The following is a description of a gene set: studied in species Mus musculus Mouse Gene Set: GOBP_CARDIAC_CHAMBER_DEVELOPMENT The progression of a cardiac chamber over time, from its formation to the mature structure. A cardiac chamber is an enclosed cavity within the heart., and this is the list of marker genes: Gsk3a, Gja5, Fhl2, Mir20a, Bmp7, Hand2, Fgfr2, Slit3 (slit guidance ligand 3), Ovol2, Lrp2, Mesp1, Myl2, Npy2r, Cpe, Zmpste24, Myl3, Sav1, Msx2, Zfpm1, Gata6, Tgfb2, Hey1, Zbtb14, Nfatc1, Robo1, Heg1, Tek, Nrp2, Rnls, Cplane1, Epor, Adgrg6, Adprhl1, Bmp2, Shox2, Matr3, Mdm2, Dsp, Eva1a, Foxc2, Arid1a, Nog, Pou4f1, Cfc1, Ptk7, Robo2, Wnt5a, Tgfbr3, Epo (NCBI Gene Id 13856), Ccn1, Foxh1, Tnni3, Ank2, Sox11, Plxnd1, Ednra, Bmp4, Cxcr4, Rbpj, Smo, Acvr1, Dnm2, Scn5a, Dvl3 (dishevelled segment polarity protein 3), Tnnc1, Wnt2 (wingless-type MMTV integration site family, member 2), Pde2a, Smarcd3, Hoxa13, Id2, Nsd2, Ccm2l, Tpm1, Fzd1, Sall1, Tgfbr2, Ctnnb1, Kcnj8, Tmem65, Sall4, Dand5, Ly6e, Bmpr1a, Myh10, Greb1l, Ap2b1 (NCBI Gene Id 71770), Gata4, Bmpr2, Tbx1, Mef2c, Tab1, Mir92-1, Ahr, Grhl2, Dll4, Bmp10, Tbx5 (NCBI Gene Id 21388), Rbm15, Sox4, Hif1a, Mir19a, Smad6 (SMAD family member 6), Dnah11, Mdm4 (NCBI Gene Id 98570), Tgfb1, Ptcd2, Tbx20 (NCBI Gene Id 77243), Myh6, Ryr2 (NCBI Gene Id 77553, ryanodine receptor 2, cardiac), Isl1, Med1, Hectd1, Mir19b-1, Wnt11, Parva, Ift88, Kif7, Rxra, Cited2, Stra6, Mybpc3, Rbp4, Aplnr, Maml1, Mks1, Fkbp1a, Sos1, Tbx3, Dctn5, Pcsk5, Adamts6, Adamts1, Prox1, Foxc1, Pitx2, Lmo4, Nrg1, Sfrp2, Hes1, Xirp2, Heyl, Tnni1, Tgfbr1 (NCBI Gene Id 674605), Srf, Fgf9 (NCBI Gene Id 252883), Col11a1, Mir18, Smarca4, Mir17, Hand1, Luzp1, Chd7, Nphp3, Notch1, Tbx2, Ppp1r13l, Zfpm2, Nos3, Gata3, Fgf8, Snx17, Tnnt2, Ndst1, Prdm1, Trp53, Notch2, Trip11, Klk1b1, Sufu, Naglu, Cav3, Hand2os1, Eng, Sema3c, Pcdha9, Frs2, Lrp6, Foxf1, Pkp2, Npy5r, Myocd, Vangl2, Nrp1, Slit2, Bmp5, Hey2, Ltbp1, Egln1, Cntrl, Fuz, Fgfrl1, Pax8, Nprl3, Ube4b, Dhrs3, Nkx2-5, Fzd2, Smad7, Lrp1, Myh7, Adamts19, Smad4, Jag1, Kcnk2